The following is a description of a gene set: studied in species Mus musculus from publication Ma X, Husain T, Peng H, Lin S, Mironenko O, Maun N, Johnson S, Tuck D, Berliner N, Krause DS, Perkins AS (PMID 12130493) With the goal of creating a resource for in-depth study of myelopoiesis, we have executed a 2-pronged strategy to obtain a complementary DNA (cDNA) clone set enriched in hematopoietic genes. One aspect is a library subtraction to enrich for underrepresented transcripts present at early stages of hematopoiesis. For this, a hematopoietic cDNA library from primary murine bone marrow cells enriched for primitive progenitors was used as tester. The subtraction used 10 000 known genes and expressed sequence tags (ESTs) as driver. The 2304 randomly picked clones from the subtracted cDNA libraries represent 1255 distinct genes, of which 622 (50%) are named genes, 386 (30%) match uncharacterized ESTs, and 247 (20%) are novel. The second aspect of our strategy was to complement this subtracted library with genes known to be involved in myeloid cell differentiation and function. The resulting cDNAs were arrayed on polylysine-coated glass slides. The microarrays were used to analyze gene expression in primary and cultured murine bone marrow-derived progenitors. We found expression of various types of genes, including regulatory cytokines and their receptors, signal transduction genes, and transcription factors. To assess gene expression during myeloid differentiation, we examined patterns of change during induced differentiation of EML cells. Several hundred of the genes underwent fluctuations in expression level during myeloid cell differentiation. The complete database, accessible on the World Wide Web at http://yale130132115135.med.yale.edu/, allows for retrieval of information regarding these genes. Our microarray allows for genomewide expression analysis of myeloid stem cells, which will help in defining the regulatory mechanisms of stem cell differentiation. Genes up-regulated during myeloid differentiation induced by tretinoin (ATRA) and IL3 in the EML cell line (myeloid progenitor). Human Gene Set: MA_MYELOID_DIFFERENTIATION_UP, and this is the list of marker genes: CCT5, MDM2, C1QA, ADA, FGFR4, GNAS, SH2D3C, MTF2, PPIA, RB1, VASP, BNIP3L, CALR, PTPN11, PRG2, CCL19, JCHAIN, KLF13, CDKN1A (NCBI Gene Id 1026), PPM1G, ELAVL3, ITGB7, EEF1A1, RAN, EMP3, NCL, APBA1, SMAD5, TIAL1, MT1F, KLF9, GZMB, DAD1, MYO1C, UBB, RGL2, IMPDH2, CREG1